The following is a description of a gene set: species: Homo sapiens Human Gene Set: IRF_Q6 Genes having at least one occurrence of the motif BNCRSTTTCANTTYY in the regions spanning 4 kb centered on their transcription starting sites. This matches the IRF1 transcription factor binding site V$IRF_Q6 (v7.4 TRANSFAC)., and this is the list of marker genes: RBMS2, NRP1, GJC1 (gap junction protein gamma 1), UBR5, PRKAG1, ZNF366, DNASE1L3, RBCK1, DLL1, PYM1, TBX1, SLC39A7, ADAM12, TMEM108, SELL, HLA-C, ACSL5, IFIT2, SLC15A3, NPR3, RRBP1, GATA6, FMR1, CCND1, ISL1, MYOG, FERRY3, CYBB, ZNF296, SLC2A5, MLLT3, AKIRIN1, BBX (BBX high mobility group box domain containing), RTP4, MS4A1, PSMB10, RTN4, SREK1, TIMD4, ECM2, KDM2A, AMTN, SIX1, SOCS1, LGALS9, KLHL13, LY86, ESR1, IRF2, CIITA, EXT1, TCF15, RAD51AP1, BATF2, TCIRG1, MAP3K11, TCF7L2, TRIM21, IRF9, ZFPM1, NOD2 (NCBI Gene Id 8135), CDIN1, CXCL10, MEIS2, GABARAP, TNFSF15, SERHL, PRKD2, HMCN1, ETV6, PSMB8, GRIA3, LGI1, USP44, RUNX1T1, NUB1 (NCBI Gene Id 51667), PARP12, NEDD4, PHF23, CYB5B, CASP7, SYNE2, THBS1, CMTR1, ADAM15, EOMES, IL22RA1, PTPRO, TAPBP, GSDMD (NCBI Gene Id 79792), TWIST1, ZBTB32, OSM, B2M, PCGF5, PARP9, SIK3, DHX58, PDGFRB, MYB (NCBI Gene Id 4602), EIF4A2, MOV10, PLEKHH2, CBX4, KLHDC7A, IFNL3, ADAR, ZEB2, PRR7, ETV5, FCGR2B (Fc gamma receptor IIb), HLA-F, DDX60, HAPLN1, GRIPAP1, ATXN7L1, PRKACA, STAG2, TMBIM4, MAPK10, HOXB4, PTK2, MUSK, LZTS2, IL18BP, FLI1, CPEB4, CCNT2, TBL1XR1, HPCAL1, ADORA3, CDK6, HIPK1, BST2, IKZF2, TFDP2, ZBP1, C12orf42, PSMA5, DGKA, TOP1, NLGN2, PCDHGC3, SAT1, ITGB7, CDH3, CREBZF, EHD1, HTR2C, MAML2, IFI44, PLP1, KMT2A, IFNB1, NPEPPS, TAPBPL, IFNL2, PURA, ISG15, PCDH7, NCF1, ZNF385A, SNX22, PITX2, NFATC1, MSX1, SLC40A1, CASK, RARG, UPF2, RORB, MIA2, PIP4K2B, RELCH (RAB11 binding and LisH domain, coiled-coil and HEAT repeat containing), WDR82, ARHGAP5, TNFSF13B, KCNIP3, TMEM229B, BCOR, EGFL6 (EGF like domain multiple 6), NT5C3A, SEMA6D, FCGR2C, STAT6, IL1RAPL1, ZCCHC24, LSP1, RAPGEF6, DIO2, NABP2, LMO2, EREG, PRDM16, FGF9, PTMA, CHST1, TLR7, CCDC6, NAALADL2, PSMA3, BHLHE22, DAPP1, PTGR3, ARF3, IFI35, HPSE2, CNTFR (NCBI Gene Id 1271), SEMA3A, F3, TLK2, SLC11A2, ATP13A1, DCLK1, ELOA2, ZSCAN2, LINC02363, DTX3L, LURAP1L, ARPP21, PIGV, KLF14, TOR1AIP1, LGALS8, ST3GAL4, ARMCX6, UBE2L6, CXCR4, KYNU, SH2B3, PLXNC1, BCL11A, CD80, ARHGEF6, DUSP10, HOXB3, STT3B, KCNQ4, FUT8, USF1, PTCHD4, CASZ1, TIFA, BTAF1